The following is a description of a gene set: studied in species Homo sapiens Human Gene Set: GOBP_MITOCHONDRIAL_DNA_REPLICATION The process in which new strands of DNA are synthesized in the mitochondrion., and this is the list of marker genes: TWNK, TEFM, MGME1, METTL4, LIG3, POLG, RRM2B, ENDOG, SSBP1, PRIMPOL, POLG2, RRM1, DNAJA3, POLRMT, DNA2